Given this list of marker genes PRDX3, FANCL, SCRN1, FBXO5, CCDC6, LZTFL1, SERPINF1, ZNF22 (zinc finger protein 22), PABPN1, STK3, CHAF1A, TOPBP1, BUB1, RRM1, SLC1A4, FBXL12, CHAF1B, SMC4, POP7, YARS1, ABCE1, ZMYM3, SCCPDH, MKI67, FIG4, YWHAQ, AURKA, CDC20 (NCBI Gene Id 991), GARS1, TARP, ZWINT, SSX2IP, B3GNT2, DNAJB6, PGRMC1, ZC4H2, DONSON, LDHA, BLM, PA2G4, PPP4R1, GNA15, ABCF2, WDR41, SLC25A46, ECT2, SF3B3, EIF4A3, CCR9, ZNF282, CENPM, TSPAN7, ADK, UBR7 (NCBI Gene Id 55148), GALNT7, MSH6, CKAP2, CSTF3, EIF2B3, TFDP1, ARMCX1, NEK2, MARCKSL1, ETFB, SF3B4, RFX5, SOX4, ALDH2, CCDC51, ABCD3, UBE2S, PBK, CCT5, HDGF, RUBCNL, PELI2, NOTCH1, GLMN, TFDP2, RBMX, LARP1, SNCA, OIP5, YEATS2, EAF2, YBX3, GCHFR, WDHD1, NHP2, AKR1A1, CHEK1, GATB, CHD4, CENPN, MCUR1, TP53BP1, DSG2, CDKN3, OPN3, FANCI, POLA1, UBE2C, ARHGAP32, RWDD2B, BAHCC1, CKS2, TTF2, CTNNAL1, ATIC, PRMT1, AGO3, ASRGL1, TMEM97, MCM6, BID, CDC7, DESI2, EXTL2, CCT6A, CSNK2B, DPP3, HELLS, HNRNPAB, PSMD4, FOXM1, ACO1, HES1, ORC6, CCNA2, PIAS2, ACTG1, STAG3, CDC6, CHST10, PSMA2, FEN1, ENPP2, PSAP, CD200, TSPYL5, NSDHL, ACOX3 (acyl-CoA oxidase 3, pristanoyl), SPAG1, ARHGAP19, HDAC2, AAGAB, RAG2, FSTL1, MCM4, RNASEH2B, ANP32A, NBN, MCAM, TCF12, PTPN2, GUCY1A1, MLLT11, EIF4A1, RAD51C, KIF18B, SMARCA4, TIPIN (NCBI Gene Id 54962), NF1, IDH3A, ALDH7A1, RCN2, UBE2A, CSNK2A1, SPRING1, NUP107, AHI1 (NCBI Gene Id 54806), CHCHD3, PIMREG, IGF2BP3, DHFRP3, TIMP2, STIL, CENPS, ZWILCH, TUBB4B, DLEU2, DDB1, ITPR2, NEDD4, BTBD3, IFT52, API5, TNFSF4, ICMT, MAD2L1, TRDMT1, PKD2, HCFC1, PEX5, IMPA2, SALL2, CUX1, CBX3, CIB2, PXMP2, here is a description of the gene set: species: Homo sapiens Human Gene Set: GSE1460_INTRATHYMIC_T_PROGENITOR_VS_NAIVE_CD4_TCELL_ADULT_BLOOD_UP Genes up-regulated in comparison of intrathymic T progenitor cells (ITTP) versus naive CD4 T cells from adult blood. from publication Lee MS, Hanspers K, Barker CS, Korn AP, McCune JM (PMID 15210650) Subpopulations of human fetal thymocyte and circulating naïve T cells were obtained through FACS sorting, including CD3-CD4+CD8- intrathymic T progenitor cells (ITTP), CD3intCD4+CD8+ \double positive\ thymocytes (DP), CD3highCD4+CD8- \single positive\ thymocytes (SP4), CD3+CD4+CD8-CD45RA+CD62L+ naive T cells from cord blood (CB4+), and CD3+CD4+CD8-CD45RA+CD62L+ naive T cells from adult blood (AB4+).